Given this list of marker genes IL33, IL26, STAT3, CSF2, MAPK14, SMAD2, TYK2, JAK1, MAPK1, ACTA2, TNFSF11, PIK3CA, RORC (RAR related orphan receptor C), BAX, MT-CO2, IL20RA, DEFB4B, DDIT3, RELA, MMP9, EPHA3, ATP6V0D2, JAK2, IL1B, SOCS3, NFKBIA, CASP3, NFATC1, STAT1, CTSK, MAPK3, MAPK8 (mitogen-activated protein kinase 8), DCSTAMP, IL17A, IL6, CCL20, MMP1, IL10RB (NCBI Gene Id 3588), CXCL8, ICAM1, MAPK9, IL10, TNF, DEFB4A (defensin beta 4A), JUN, AKT1, MPO, here is a description of the gene set: studied in species Homo sapiens IL26 signaling Human Gene Set: WP_IL26_SIGNALING